Given this list of marker genes Opn3, Opn1sw, Rgr, Opn4, Rrh, Opn1mw (NCBI Gene Id 20164), Rho, Opn5, here is a description of the gene set: studied in species Mus musculus Opsins Mouse Gene Set: REACTOME_OPSINS